Given this list of marker genes WWP1, BCL10, CDC14B, ATP2C1, KLHL8, PNRC1, CP, GLCCI1, GNA13, GNAQ, TRIO, RPP14, CEP350, GOLGA5, ARID1A, SLC16A10, NR1D2, PLEKHO2, PABPC1, ZNF367, YEATS2, APPL1, ATP11C, TFRC, CCBE1 (NCBI Gene Id 147372), NFE2L2, SETD6, SLU7, MED26, WAC, MEI4, EOGT, NEPRO, RASGEF1C, MAMDC2, DNAJA3, KCNIP3, CBX3, CUL5, NEBL, GFRA2, RASGRF2, RNF217, UBN2, ATP8B2, ARFGEF3, SCAF11, SORCS1, HNRNPL, ENTPD1, GNAI3, CHMP4B, SGCD, GGNBP2, YIPF6, SGMS1, IRF2BPL, ABRAXAS1 (abraxas 1, BRCA1 A complex subunit), AGFG1, WWTR1 (NCBI Gene Id 25937), FRYL, DENND1B, FUBP3, HNRNPK, KLF8, CLCC1, SLC17A6 (NCBI Gene Id 57084), PRKAR2B, NXT2, RBPJ (NCBI Gene Id 51580), SOX21, ADARB1, MRPL44, REP15, RNF113B (ring finger protein 113B), LYPD6B, CDYL2, ADH1B, CAMK1D, PALLD, RAB11A, JAM2, LEPROTL1, PGRMC1, CHMP2B, FAM120A, SLC39A14, C15orf61, SLC4A7, AGPAT5, NSD3, SLC30A4, ENTREP1, FOXE1, C3orf38, ZDHHC17, CDHR3, SATB2, UNC5D, SMCO3 (single-pass membrane protein with coiled-coil domains 3, NCBI Gene Id 440087), GEM, MCC, AQP4, CACNA1B, ABCA1, SALL4, GALNT7, EMX2, IBTK, FBN1, AUTS2, MAP2, ELAVL4, ECT2, ATP5MG, MAGED4, ADAM9 (NCBI Gene Id 8754), HADHB, HMGB2, MSTO1, PDE10A, MARCHF5, DAZ4, ANKRD28, CSRNP3, RCBTB2, ARK2N, USP47, EGF, LYPLA1, TLCD4, MAPK6, NBAS, CAMTA1, SP4, NKTR, NPHP1, HSPB8, FCRL2, PDK2 (pyruvate dehydrogenase kinase 2), STOX2, OR9Q1 (olfactory receptor family 9 subfamily Q member 1), DMP1, TET1, UBASH3B, CCNC, BZW1, GALNTL6, LRRC39 (leucine rich repeat containing 39), PDS5A, GZF1, CMTM8, SOWAHA, C1GALT1C1, NKAIN2, EEA1, CEP41, FAXC, SLC1A6, DAZ3, TRO, TMEM199, FNDC3B, KPNA6 (NCBI Gene Id 23633), HUS1B, UVSSA, GABRG1, BICD2, SENP8, CD2AP, CHD6, RFX7, ZNF701, TUB, RBMS3, SOX2, TENT4B (NCBI Gene Id 64282), SPTBN4, NFKB1, UBE2K, GTF2A1, HSD11B1, WDR59, NANOS1, CALM2 (calmodulin 2), NWD2, PCDH17, BPTF, TLCD3A, SMC1A, GABPA, BCL2 (BCL2 apoptosis regulator), RIMS2, VCP, SOX6, CCNDBP1, MLLT6, ZNF813, SPRTN, MSX2, MZT1, CCDC170, PURA, AGO4, FOXN3, PIP5K1B, PURB (NCBI Gene Id 5814), SERINC5, AK5 (adenylate kinase 5), B3GNT2, FRMD4A, PABPC5, CLIP4, PAX9, PAK3, ZIC3, RFC1, CNNM1, IGSF1, DLK1, SLC35A3 (solute carrier family 35 member A3), ARPC5, MSL3, MMUT, GPR158, EDA, DAZ2, TNPO1, TRPM3, IGF1, PSD3, LUM, CFL2, STS, TPST2, LEPROT, BCL11B, ISM1, RAB43, PRDM16, AMPH, TMEM255A, ONECUT2, CCNK, CAPZA2, SESN3, LBR, RBM47, PPHLN1, PKD2L2, POGLUT3, ZNF516, SLCO3A1, LAMP2, LSM14B, PLXDC2, GABBR2, QKI, NDRG3, STARD9, MRPL35 (mitochondrial ribosomal protein L35), SNCA, SPOPL, CLCN3, PWWP3B, VMA21 (vacuolar ATPase assembly factor VMA21), PLCB4, KRT15, EPHB1, TMEM123, TYR, MARCHF7, REEP1, FILIP1, TRMT12, HIPK3, XPO4, PAN2, MAP3K13, NAV3, CRB1, PI4K2B, EBF1, KMT2E, ANKRD12, MEF2C, CALB1 (NCBI Gene Id 793), ZNF10, SOD2, LRAT, USP9X, C1orf174, TUBA4A, CAMK2N1, TTN, SLC25A46 (NCBI Gene Id 91137), DENND10, KLHL5, TPP2, JKAMP, ERBB2, ENOX2, AADAT (aminoadipate aminotransferase), PKD2, CT62, MBNL3, LRP6 (NCBI Gene Id 4040), PDZRN3, MS4A12, GSPT1, CPEB1, ATXN7, PTPN4, DKK2, HOOK3, MSTN, OTOGL, LHX1, NECAP2, PRTG, RASSF5, ARID4A, RHOQ, MSN, KIDINS220, PHIP, ANK3, SLC9C1 (NCBI Gene Id 285335), CENPK, CSTPP1, RUNX1, ECPAS, HAPSTR1, ATF7IP, FLRT3, PTBP1, EDIL3, ORC5, ANKS1B, ZBTB43, HIPK1, KCTD1, POLR3F, SLAMF1, SLC36A4, SPTSSB, PTPRZ1, ACVR1, MTDH, UBE2I, AGO3, KCTD21, MIER1, SUN2, RALA (RAS like proto-oncogene A), PTPRR, PRRG1, BACH2, CNKSR2, DCP1A, NR4A2, ART3, CTTNBP2NL (NCBI Gene Id 55917), APC, APBB2, BCLAF3, PBRM1, GMFB, NPAT, FAN1, ENDOD1, CLRN1, GAPT, TMEM106B, PCDH7, LPGAT1, C1orf21, LNPEP, NEDD1, PRKACB, TAOK1, PCDH19, PDE3A, MAGED4B, SCAF8, ELK4, C3orf70, CDC42EP3, DAAM1, NOXRED1, IKZF5, XKR4, ETV6, INTS13, ZFYVE26, PBX1, CLCN5, ZBTB11, PLEKHA8, DPY19L3, ADAM19, VGLL3, TRDN, HERC3, MBLAC2, GASK1B, CCDC179, STIM2, HSPA13, CAMK4, GUCY1A2, CNOT7, PCDHGA7, USO1, THSD7A, PRICKLE2 (prickle planar cell polarity protein 2), DAB2IP, DGKE (diacylglycerol kinase epsilon), CNTN5, CCNYL1 (NCBI Gene Id 151195), FOXR2, PLXNA4 (NCBI Gene Id 91584), UCHL5, TMEM267, ZBTB10, SHB, GPC6, KCNA1, ANO3, PHF20, MBNL1, CGGBP1, PTP4A1, DDX24, VPS36, LRRN1, CLEC3B, GABRA4, LAYN, MKX, ATP9A, KCNB1, UBR1, PCSK6, PLK4, MAN1A1, SMIM9, ERI2, RAB23, DKK3, INTS6L, PABPC3, INO80D, BRWD3, GSN, CCDC91, CCDC9B, C1RL, AOAH, ZBTB20, SYT7, U2SURP, GPATCH2L, RARG, TNRC6A, ACSL4, VGLL4, FHIP2B, RXFP1, GSTA2, CBLB, PEX5L, IFI44L, MIPOL1, NELL1, SENP1, TMLHE, CHRM2, CACNA1C, ZNF366, RAB3IP, TRIQK (triple QxxK/R motif containing), RAP2C, ADAM10, CADM2, here is a description of the gene set: from publication Chen Y, Wang X (PMID 31504780) Human Gene Set: MIR450B_5P studied in species Homo sapiens Genes predicted to be targets of miRBase v22 microRNA hsa-miR-450b-5p in miRDB v6.0 with MirTarget v4 prediction scores > 80 (high confidence targets).